Given this list of marker genes Rgs12, Nckap1, Sgk1, Mllt3, Rab27a, Rab32, Mn1, Vamp4, Pcbd2, Tcf4, Pgrmc1, Mtus1, Cpne3, Recql, Tpm4, Gas2l1, Crip2 (cysteine rich protein 2), Tgfbr1, Lrrc58, here is a description of the gene set: Dominant RUNX1 inhibition has been proposed as a common pathway for CBF leukemia. CBF beta-SMMHC, a fusion protein in human acute myeloid leukemia (AML), dominantly inhibits RUNX1 largely through its RUNX1 high-affinity binding domain (HABD). However, the type I CBF beta-SMMHC fusion in AML patients lacks HABD. Here, we report that the type I CBF beta-SMMHC protein binds RUNX1 inefficiently. Knockin mice expressing CBF beta-SMMHC with a HABD deletion developed leukemia quickly, even though hematopoietic defects associated with Runx1-inhibition were partially rescued. A larger pool of leukemia-initiating cells, increased MN1 expression, and retention of RUNX1 phosphorylation are potential mechanisms for accelerated leukemia development in these mice. Our data suggest that RUNX1 dominant inhibition may not be a critical step for leukemogenesis by CBF beta-SMMHC. Mouse Gene Set: KAMIKUBO_MYELOID_MN1_NETWORK studied in species Mus musculus from publication Kamikubo Y, Zhao L, Wunderlich M, Corpora T, Hyde RK, Paul TA, Kundu M, Garrett L, Compton S, Huang G, Wolff L, Ito Y, Bushweller J, Mulloy JC, Liu PP (PMID 20478528) Network of differentially expressed myeloid genes centered around MN1.